Given this list of marker genes PRKACB, LARS2, VPS13B, LZTR1, NF1, TUBB3, POP1, WNT4, CUL4B, SOS1, SHOX, PEX2, MAP2K1, POR, EVC2, BRAF, PSMD12, GLI1, WDR11, MAPK1, LMX1B, RSPRY1, NUP107, CBL, RAF1, ASPH, DYNC2LI1, PEX1, BPTF (bromodomain PHD finger transcription factor), CHST3, IDH1, SIL1 (NCBI Gene Id 64374), PTPN11, GJA1, PEX5, PRMT7, SFRP4, SRY, BCOR, EVC, CLCF1, IL6ST, KDM5C, PRKACA, LMBRD2, MAP2K2, NOG, IDH2, SHOC2, SPRED2, KRAS, FBXO11, PTH1R, FGF9, HEATR3, here is a description of the gene set: Abnormal positioning in which the elbows are turned out. Human Gene Set: HP_CUBITUS_VALGUS Cubitus valgus species: Homo sapiens